Given this list of marker genes Nceh1, Peds1, Far1, Ephx2, Alox5, Pla2g4a, Plaat3, Pla2g7, Lpcat2, Fasn, Lipe, Pla2g4c, Gnpat, Pex7, Ephx3, Pla2g6, Agmo, Ephx1, Pla2g5, Dhrs7b, Agps, Chpt1, Alox12, Tmem86b, Pla2g10 (phospholipase A2, group X), Pxmp4, Selenoi, Plaat1, here is a description of the gene set: The chemical reactions and pathways involving organic ethers, any anhydride of the general formula R1-O-R2, formed between two identical or nonidentical organic hydroxy compounds. Mouse Gene Set: GOBP_ETHER_METABOLIC_PROCESS species: Mus musculus